The following is a description of a gene set: from publication Chen Y, Wang X (PMID 31504780) studied in species Homo sapiens Human Gene Set: MIR3935 Genes predicted to be targets of miRBase v22 microRNA hsa-miR-3935 in miRDB v6.0 with MirTarget v4 prediction scores > 80 (high confidence targets)., and this is the list of marker genes: RNF125, TBC1D16, STC1, FGG, CSMD3, CNOT7, ZBTB4, TXLNG, FRMD6, EPHA4, LTBP1, BID, NCBP3, ZNF660, GOLPH3, IAH1, MYOM1, CUL2, PTHLH, PYROXD1, ZNF512B, NUP155, TDRP, FUCA1, PCM1, COL15A1 (collagen type XV alpha 1 chain), TOGARAM1, CYP20A1, KRTAP20-3, POU3F2, GRIP1, THEMIS, SAMSN1, LYRM2, OTX1, PCSK5, EDIL3, TRIM56, RGS5, LHFPL3, IGFBP7, ARHGEF35, PALLD, SLC10A7, KIF16B, CDKL3, RNF149, NDUFAF4, RPS10-NUDT3, RAG2, TRDMT1, NUDT3, SYT15, PABIR3, AHDC1, SYNPO2, SLAIN2, TSPYL5, UQCRQ, KCTD9, KPNA4, C5orf24, SVIL, IRAK1BP1, SCRN1, SOWAHA, MED13, HECTD2, SLC9A7, SALL4, TG, GNB4, YME1L1, NAALADL2, MAPK6, ANXA6, RBL1, SLC22A24